Given this list of marker genes PRDX2, BTN2A2, SPINK5, PRDM1, DTX1, ZEB1, FOXN1, FOXP3, INPP5D, IL36B, BMP4, IL2RA, SFRP1, CD2, ZBTB7B, BAD, LOXL3, PPP2R3C, SMARCA4, RHOA, SYK, IL7, CR1, ACTL6B, MDK, CYP26B1 (NCBI Gene Id 56603), GATA3, KCNK18, ZAP70, ANXA1, NKAP, SLC46A2, SMARCA2, SMARCE1, ZMIZ1, TLR9, IL7R, GLI2, NFKBIZ, HLA-G, DUSP10, HLA-DRB1, MIR21, CD46, CD28, PSG9 (NCBI Gene Id 91052), MALT1, FANCD2, IRF1, TNFSF18, FOXO3, SMARCC1, AXL, ADA (adenosine deaminase), IFNG, RIPK2, CLPTM1, RAG2, AP3B1, ACTL6A, IL21, STAT5B, SHB, IL23R, IL1RL2, CLEC4G (NCBI Gene Id 339390), ZBTB16, IL18, SOCS1, IL15RA, DDRGK1, TBX21, NDFIP1, RNF41, SMARCD2, FBXO7 (F-box protein 7), IKZF3, ARID2, BRD2, PBRM1, CD27, MIR30B, LGALS1, SLC4A2, PGLYRP2, SOX12, FGL2, SPI1, FANCA, RHOH, TNFSF4, IHH, IL23A, BTK, CD86, SASH3, BRD4, CARD11, CD83 (NCBI Gene Id 9308), KAT2A, HLA-DRA, EGR3, RUNX3, SLAMF8, IL27, JUNB, ZFP36L2, STAT5A, CCL19, NFKBID, ZNF683, RC3H1, IL4R, CD69, TOX, KLHL25, XBP1, PTPN2 (protein tyrosine phosphatase non-receptor type 2), PGLYRP3, PRELID1, ZC3H8, SMARCD3, BRD7, SOD1, ZC3H12A, EP300 (NCBI Gene Id 2033), HLX, CBFB, ARID1A, AP3D1, CD80, PRKCZ, PTPN6, NCKAP1L, HLA-DOA, LCK, CCR2, CYLD (NCBI Gene Id 8010), AMBRA1, RUNX1, ASCL2, PNP, SOCS5, BATF, ZBTB1, BCL6, ACTB, DROSHA, IFNB1, IFNA2, WNT10B, HMGB3, KAT5, MIR17HG, SOX4, TGFB1, IRF4, INHBA, CD74, IFNL1 (NCBI Gene Id 282618), PTPRC, PRKDC, NLRP3, TNFSF9, PCID2, GPR65, LEF1, ADAM8, TMEM131L, MMP14, IL4I1, RARA, GAS6, RC3H2, IL4, INHA, SMARCD1, CAMK4, SOS1, SMAD7, SHH, PHF10, METTL3, TGFBR2, RAG1, SOX13, LGALS9, BRAF, NRARP, IL12B, IL2, CDKN2A, ARID1B, IL15, SH3RF1, CRTAM, PCK1, SMARCC2, ID2, SOS2, LAG3, NFAM1, LILRB2, TCF7, IL2RG, ZFP36L1, FOXJ1, RASGRP1, VSIR, GLI3, HMGB1, LILRB4, IL10, SART1, IL12RB1, VNN1, CTLA4, PIK3R6, SMARCB1, ABL1, OPA1, ERBB2, ITPKB, JAK3, XRCC6, TESPA1, FCRL3, PGLYRP1, here is a description of the gene set: Any process that modulates the frequency, rate or extent of lymphocyte differentiation. Human Gene Set: GOBP_REGULATION_OF_LYMPHOCYTE_DIFFERENTIATION species: Homo sapiens